The following is a description of a gene set: Human Gene Set: BANDRES_RESPONSE_TO_CARMUSTIN_MGMT_48HR_UP studied in species Homo sapiens Genes up-regulated in T98G cells (glioma, express MGMT) by carmustine at 48 h. Chemotherapy with the alkylating agent BCNU (1,3-bis (2-chloroethyl)-1-nitrosourea) is the most commonly used chemotherapeutic agent for gliomas. However, the usefulness of this agent is limited because tumor cell resistance to BCNU is frequently found in clinical brain tumor therapy. The O6-methylguanine-DNA methyltransferase protein (MGMT) reverses alkylation at the O6 position of guanine and we have reported the role of MGMT in the response of brain tumors to alkylating agents. However, the different mechanisms underlying the patterns related to MGMT remain unclear. To better understand the molecular mechanism by which BCNU exerts its effect in glioma cell lines according MGMT expression, we used microarray technology to interrogate 3800 known genes and determine the gene expression profiles altered by BCNU treatment. Our results showed that treatment with BCNU alters the expression of a diverse group of genes in a time-dependent manner. A subset of gene changes was found common in both glioma cell lines and other subset is specific of each cell line. After 24 h of BCNU treatment, up-regulation of transcription factors involved in the nucleation of both RNA polymerase II and III transcription initiation complexes was reported. Interestingly, BCNU promoted the expression of actin-dependent regulators of chromatin. Similar effects were found with higher BCNU doses in MGMT+ cell line showing a similar mechanism that in MGMT-deficient cell with standard doses. Our data suggest that human glioma cell lines treated with BCNU, independently of MGMT expression, show changes in the expression of cell cycle and survival-related genes interfering the transcription mechanisms and the chromatin regulation. from publication Bandres E, Andion E, Escalada A, Honorato B, Catalan V, Cubedo E, Cordeu L, Garcia F, Zarate R, Zabalegui N, Garcia-Foncillas J (PMID 15980968), and this is the list of marker genes: TUBB, SMPD2, UGT8, GPR65, SMARCD1, SLC6A2, CLTCL1, SNRPB2, GOLGA4, CCL2, GNRHR, SLC16A2, SNAPC1, GCM1, PIK3R3, CNTNAP1, SNAPC3, CTNNAL1, SLC10A1 (solute carrier family 10 member 1)